The following is a description of a gene set: Regulation of Insulin-like Growth Factor (IGF) transport and uptake by Insulin-like Growth Factor Binding Proteins (IGFBPs) species: Homo sapiens Human Gene Set: REACTOME_REGULATION_OF_INSULIN_LIKE_GROWTH_FACTOR_IGF_TRANSPORT_AND_UPTAKE_BY_INSULIN_LIKE_GROWTH_FACTOR_BINDING_PROTEINS_IGFBPS, and this is the list of marker genes: MELTF, APOE, F5, SPARCL1, NUCB1, CALU, KNG1, MATN3 (NCBI Gene Id 4148), KLK2, TIMP1, WFS1, LAMB1, AHSG, MIA3, TGOLN2, CST3 (cystatin C), GAS6, SCG2, P4HB, MXRA8, FBN1, SERPINA1, AFP, CHGB, MGAT4A, SPP2, F2, CTSG, CSF1, FN1, BMP4, VGF, PAPPA2, KLK3, MBTPS1 (NCBI Gene Id 8720), SDC2, KLK13, PNPLA2, AMTN, SERPINC1, CDH2, IGFBP5, NOTUM, ANO8, TF, IGFBP4, STC2, MEPE, IL6, SPP1, SERPIND1, MMP2, ALB, PCSK9, TMEM132A (NCBI Gene Id 54972), SHISA5, IGF1, IGFBP3, GOLM1, HRC, LAMC1, APOA5 (NCBI Gene Id 93561), PROC, DMP1, CKAP4, PENK, CHRDL1, IGFBP2, MSLN, RCN1, PLG, BPIFB2, ENAM (enamelin), CCN1, IGF2, LAMB2, MEN1, FAM20C, AMBN, LGALS1, VCAN, MMP1, IGFBP6, PDIA6, FUCA2, FGA, PRSS23, PAPPA, CP, APOA1, FGF23, IGFALS, SCG3, DNAJC3, C3, FSTL3, C4A (complement C4A (Chido/Rodgers blood group)), TNC, ITIH2, APOA2, APP, IGFBP1, KTN1, PRKCSH, APOB, APLP2, MFGE8, IGFBP7, AMELX, GZMH, APOL1 (apolipoprotein L1), FSTL1, LTBP1, SERPINA10, FGG, VWA1, EVA1A, QSOX1, BMP15, ADAM10, FAM20A, KLK1, HSP90B1, GPC3